The following is a description of a gene set: species: Homo sapiens Human Gene Set: GOBP_RESPONSE_TO_ANGIOTENSIN Any process that results in a change in state or activity of a cell or an organism (in terms of movement, secretion, enzyme production, gene expression, etc.) as a result of an angiotensin stimulus. Angiotensin is any of three physiologically active peptides (angiotensin II, III, or IV) processed from angiotensinogen., and this is the list of marker genes: FAT1, SLC30A10, PRKCA, CAMK2A, INHBA, MIR145, CAV1, MAS1, AHCYL1 (NCBI Gene Id 29039), CA2, NFKB1, RAC1, RELA, FAM114A1, NFE2L2, NONO, MAP3K7, ACTN2, COL3A1, PRKD1, ROCK2, DDR2, SLC26A6, NPPA, AGTR1, PRKCG, AGT, SRC, AGTR2, KL, MIR143, AGTRAP, CYBB, SMAD3, CDC6, PLA2G2A, RAP1GDS1, MIR27B, CYBA, COMT, HSF1, ACE, PRKCD, PPP3CA, PTPN1, ROCK1